The following is a description of a gene set: The formation of a protein homotrimer, a macromolecular structure consisting of three noncovalently associated identical subunits. Human Gene Set: GOBP_PROTEIN_HOMOTRIMERIZATION studied in species Homo sapiens, and this is the list of marker genes: MIF, HLA-G, PXDN, P2RX7, PNPT1, SLC1A2, SIGMAR1, CLYBL (citramalyl-CoA lyase), MLKL (NCBI Gene Id 197259), SLC1A5, STEAP4, ALOX5AP, P2RX3, ITLN1, SCARA5